The following is a description of a gene set: studied in species Mus musculus Mouse Gene Set: GOBP_SMOOTH_MUSCLE_CONTRACTION A process in which force is generated within smooth muscle tissue, resulting in a change in muscle geometry. Force generation involves a chemo-mechanical energy conversion step that is carried out by the actin/myosin complex activity, which generates force through ATP hydrolysis. Smooth muscle differs from striated muscle in the much higher actin/myosin ratio, the absence of conspicuous sarcomeres and the ability to contract to a much smaller fraction of its resting length., and this is the list of marker genes: Atp2b4, Shc1, Nmur1, Pawr, Htr1d, Chrnb4 (cholinergic receptor, nicotinic, beta polypeptide 4), Dock4, Tbxa2r, Flt1, Prkg1, Atp1a2, Adra1a, Oxt (NCBI Gene Id 18429), Cacna1c, Npy2r, Slc8a1, Tacr3, Pde4d, Edn3, Tbx3, Spx, Trpv1, Gdnf, Cacna1g, Apbb2, Sphk1, Sulf1, Ghrl, Htr2a, Prok2, Tpcn2, Irag1, Rock2, Sstr2, Ghsr, Ptgs2, Kit, Tacr1, Trpa1, Mylk, Itga2, Comp, Map2k1, Atp2b1, Drd2, Gucy1a1 (NCBI Gene Id 80637), Rgs2, Sulf2, Pde4b, Chrna3, Scn11a, Htr2b, Adrb2, Bdkrb2, Tacr2 (tachykinin receptor 2), Mkks, Dlg1, Apbb1, Adra2a, Calca, Chrm3, Ednra, Ptger3, Tnni3 (troponin I, cardiac 3), Npy1r, Acta2, Cald1, Drd1, Tbx2, Chrm2, Grip2, Myh11, Neurog1 (NCBI Gene Id 18014), P2rx2, Agt, Cd38, Npnt, Sod1, Bbs2, Edn2, Setd3, Ada (NCBI Gene Id 11486), Adrb1, Chrnb2, Myocd, Smpd3, Gper1, Oxtr, P2rx3, Rap1gds1, Tshz3, Htr7, Kcnma1, Abat, Ptgs1, Adra2b, Zdhhc21, Edn1, Dock5, Pla2g6, Stub1, Adora2b, Ednrb, Nmu, F2r, Lck, Ormdl3, Cttn, Adra2c, Scnn1b, Ptafr, Calcrl, Srf, P2rx1 (NCBI Gene Id 18568), Ptger4, Arhgap42, Fkbp1b, Rhoa, Tifab, Cav1